Given this list of marker genes FMR1, IL2RA, NOG, MAP3K7, COL3A1, RNF13, FLNA, PTPN2, ASXL1 (ASXL transcriptional regulator 1), GJB6, POR, NONO, CHST3, PTPN22, ANKRD55, MYL11, CD247, PQBP1, BMP6, GDF5, B3GAT3, STAT4, IL2RB, HFE, here is a description of the gene set: species: Homo sapiens Abnormal metacarpophalangeal joint morphology An anomaly of a metacarpophalangeal joint. Human Gene Set: HP_ABNORMAL_METACARPOPHALANGEAL_JOINT_MORPHOLOGY